Given this list of marker genes Ep300, Hif3a, Hif1a, Epas1 (NCBI Gene Id 13819), Cited2, Arnt, here is a description of the gene set: Regulation of gene expression by Hypoxia-inducible Factor species: Mus musculus Mouse Gene Set: REACTOME_REGULATION_OF_GENE_EXPRESSION_BY_HYPOXIA_INDUCIBLE_FACTOR